The following is a description of a gene set: Human Gene Set: GOBP_POSITIVE_REGULATION_OF_SYNAPTIC_TRANSMISSION_GLUTAMATERGIC studied in species Homo sapiens Any process that activates, maintains or increases the frequency, rate or extent of glutamatergic synaptic transmission, the process of communication from a neuron to another neuron across a synapse using the neurotransmitter glutamate., and this is the list of marker genes: STXBP1, NRXN1, KMO, CACNG5, GRIN2C, GRIN1, DRD1, NTRK1, NLGN1, DTNBP1, IQSEC2, NLGN2, TNR, SHANK3, CACNG8, NPS, CCL2, RELN, RAB3GAP1, CACNG3, GRIN2B, NLGN3, CACNG7, TSHZ3, CACNG4, ADORA2A, CACNG2, GRIN2D, CCR2, HDAC6, GRIN2A, PTK2B